The following is a description of a gene set: Human Gene Set: REACTOME_PKA_ACTIVATION_IN_GLUCAGON_SIGNALLING species: Homo sapiens PKA activation in glucagon signalling, and this is the list of marker genes: ADCY6 (NCBI Gene Id 23320), ADCY3, ADCY1, ADCY7, GNAS, PRKAR2A, PRKAR1A, PRKACA, PRKACB, ADCY9, PRKAR2B, ADCY4, PRKAR1B, ADCY5, PRKACG, ADCY2, ADCY8